Given this list of marker genes FGF20, FGF4, FGF2, FGF1, FRS2 (NCBI Gene Id 10818), GRB2, FGF16, PTPN11, FGF8, FGF5, FGF23 (fibroblast growth factor 23), FGF6, SOS1, HRAS, NRAS, FGF9, FGF22, FGFR2, FGF3, FGF7, FGF10 (fibroblast growth factor 10), FGF17, FRS3, KRAS, FGF18, here is a description of the gene set: species: Homo sapiens Human Gene Set: REACTOME_FRS_MEDIATED_FGFR2_SIGNALING FRS-mediated FGFR2 signaling